The following is a description of a gene set: The directed movement of sodium ions from inside of a cell, across the plasma membrane and into the extracellular region. studied in species Homo sapiens Human Gene Set: GOBP_SODIUM_ION_EXPORT_ACROSS_PLASMA_MEMBRANE, and this is the list of marker genes: ATP1A2, ATP1B3, SLC4A4, FXYD6, FXYD3, NPPA, ATP1A3, ATP1B2, FXYD7, FXYD2, ATP4B, FXYD5, SLC8A1, FXYD6P3, SLC9A1, ATP1B1, FXYD4, ATP12A, ATP1A4, FXYD1, ATP4A, ATP1A1